Given this list of marker genes IL16, CD22, CD74, FYN, PLSCR1, PLSCR4, LCK, SPG21, HLA-DRB1, here is a description of the gene set: Human Gene Set: GOMF_CD4_RECEPTOR_BINDING studied in species Homo sapiens Binding to a CD4, a receptor found on the surface of T cells, monocytes and macrophages.